Given this list of marker genes Lypd11, Pram1, Itgam, Bcr (NCBI Gene Id 71258), Itgb2, Spi1, Lypd10, Ptafr, Abr, Itgb2l, Syk, Cd177, here is a description of the gene set: Mouse Gene Set: GOBP_REGULATION_OF_NEUTROPHIL_DEGRANULATION Any process that modulates the frequency, rate, or extent of neutrophil degranulation. studied in species Mus musculus